The following is a description of a gene set: species: Mus musculus Mouse Gene Set: GOMF_UNIPORTER_ACTIVITY Catalysis of the transport of a single molecular species across a membrane; transport is independent of the movement of any other molecular species., and this is the list of marker genes: Slc2a4, Mcu, Slc17a8, Slc2a8, Mfsd1, Slc16a12, Slc17a6, Slc17a7, Ucp2, Slc17a9 (NCBI Gene Id 71857)